The following is a description of a gene set: Imatinib is approved for treatment of cancers carrying primary mutations in the KIT receptor. Imatinib binds and inhibits the inactive state of the receptor, including the conformation promoted by exon 11 mutations that relieve the auto-inhibition of the WT protein. Resistance to imatinib arises due to the polyclonal expansion of subpopulations bearing secondary KIT mutations in the ATP binding pocket or the activation loop of the protein. Reactome Pathway: Imatinib-resistant KIT mutants part of: Drug resistance of KIT mutants species: Homo sapiens, and this is the list of marker genes: KIT (KIT proto-oncogene, receptor tyrosine kinase)